The following is a description of a gene set: Human Gene Set: GOMF_ATP_ACTIVATED_INWARD_RECTIFIER_POTASSIUM_CHANNEL_ACTIVITY species: Homo sapiens Enables the transmembrane transfer of a potassium ion by an inwardly-rectifying voltage-gated channel, where the inward rectification is due to a voltage-dependent block of the channel pore by ATP. An inwardly rectifying current-voltage relation is one where at any given driving force the inward flow of K+ ions exceeds the outward flow for the opposite driving force., and this is the list of marker genes: KCNJ10, KCNJ8, KCNJ11, ABCC8, ABCC9, KCNJ1